Given this list of marker genes Cyp3a11, Cyp4f18, Cyp4a12a, Cyp3a41b, Cyp3a57 (NCBI Gene Id 622127), Cyp3a25, Cyp4a10, Cyp4a12b, Cyp3a16, Cyp2s1, Cyp4f40, Cyp4a32, Cyp3a44, Cyp2u1, Cyp4f14, Cyp3a41a, Cyp3a59, Cyp4f39, Cyp2w1, Cyp4a30b, Cyp3a13, Cyp4a29, Cyp4b1, Cyp2d22 (NCBI Gene Id 56448), Cyp4a14, Cyp4f15, Cyp4a31, here is a description of the gene set: species: Mus musculus Miscellaneous substrates Mouse Gene Set: REACTOME_MISCELLANEOUS_SUBSTRATES